The following is a description of a gene set: species: Mus musculus The chemical reactions and pathways resulting in the breakdown of hyaluronan, the naturally occurring anionic form of hyaluronic acid. Hyaluronan is a type of non-sulfated glycosaminoglycan composed of the repeating disaccharide unit beta(1,4)-D-glucuronic acid-beta(1,3)-N-acetyl-D-glucosamine. Mouse Gene Set: GOBP_HYALURONAN_CATABOLIC_PROCESS, and this is the list of marker genes: Hyal2, Tgfb1, Hyal5, Cemip2, Hyal3, Gusb, Slc9a1, Hmmr, Spam1, Stab2, Hyal1, Hyal6, Cemip, Hexa, Cd44, Hyal4, Lyve1, Fgf2 (fibroblast growth factor 2), Hexb